Given this list of marker genes Tubb1, Slc7a8, Slc16a10, Serpina7, Slc3a2, Abcc2, Slc16a2, Slc7a5, Crym, Slc17a4, Slco1c1, here is a description of the gene set: The directed movement of thyroid hormone into, out of or within a cell, or between cells, by means of some agent such as a transporter or pore. Mouse Gene Set: GOBP_THYROID_HORMONE_TRANSPORT studied in species Mus musculus